The following is a description of a gene set: Reactome Pathway: Translocation of ZAP-70 to Immunological synapse This event has been computationally inferred from an event that has been demonstrated in another species.<p>The inference is based on the homology mapping from PANTHER. Briefly, reactions for which all involved PhysicalEntities (in input, output and catalyst) have a mapped orthologue/paralogue (for complexes at least 75% of components must have a mapping) are inferred to the other species. studied in species Mus musculus electronically inferred by orthology from the curated human pathway part of: TCR signaling, and this is the list of marker genes: Lck, Cd3e, Ptpn22 (NCBI Gene Id 19260), Cd3g, Cd3d